The following is a description of a gene set: species: Homo sapiens Marker genes curated from the annotated cluster as represented in the Descartes Human Gene Expression During Development database. The gene expression program underlying the specification of human cell types is of fundamental interest. The study authors generated human cell atlases of gene expression and chromatin accessibility in fetal tissues. For gene expression, the study authors applied three-level combinatorial indexing to >110 samples representing 15 organs, ultimately profiling ~4 million single cells. The study authors leveraged the literature and other atlases to identify and annotate hundreds of cell types and subtypes, both within and across tissues. Our analyses focused on organ-specific specializations of broadly distributed cell types (such as blood, endothelial, and epithelial), sites of fetal erythropoiesis (which notably included the adrenal gland), and integration with mouse developmental atlases (such as conserved specification of blood cells). These data represent a rich resource for the exploration of in vivo human gene expression in diverse tissues and cell types. from publication Cao J, O'Day DR, Pliner HA, Kingsley PD, Deng M, Daza RM, Zager MA, Aldinger KA, Blecher-Gonen R, Zhang F, Spielmann M, Palis J, Doherty D, Steemers FJ, Glass IA, Trapnell C, Shendure J (PMID 33184181) Human Gene Set: DESCARTES_MAIN_FETAL_BIPOLAR_CELLS, and this is the list of marker genes: PRICKLE2, GLRA1, CRYBG3, C3orf70, NCKAP5, WASF3-AS1, GABRB3, ZNF385B, YPEL3-DT (NCBI Gene Id 283901), NRG1-IT3, GUSBP4, MIR3671, MACROD2-AS1, LHX4, ENSG00000212302, LACTBL1, ENSG00000267448, GNL2P1, GRIK1-AS1, MAP7, DSCAM, LINC02821, RNU6-116P, CADPS, SMIM36, KCTD6, LINC01291, NIPAL4-DT, LINC01750, MACROD2, ENSG00000259541, AGAP1, BSPH1, FEZF2, TDRD6, TMEM132E, CACNA2D4, ZNF223, GSG1, GABRR1, ASIC4, LINC00469, NYAP2, TMEM196, ZNF804B, VSX1, MRPS30-DT, TAFA4, VSX2, ENSG00000249419, LINC01896, LINC03098, DSCAM-IT1, HSPA8P11, CABP2, TRMT9B, C15orf32, MACROD2-IT1, LRRC1, SERTM1, AIMP1P1, ZPBP, CDH20, ENSG00000227863, FAM234B, NFIB, RN7SL83P, GRIK1, LINC01933, NRG1-IT1, ELSPBP1, RPL11P1, TRPC7, RPL31P46, ACKR1, RSF1-IT2, ARSH, KRT8P15, CA10, TMEM215, RPL14P2, RN7SL754P, SV2B, NRG1, HCN2, ENSG00000225647, GABRR3, LINC03107, B3GLCT, FSTL5, CYP2C8 (NCBI Gene Id 1558), TRPC7-AS2